Given this list of marker genes Homer1, Slc8b1, Cracr2a, Atp2c2, Tmc1, Ripk1, F2rl3, Htr1a, Galr2, Drd4, Rgs9, Lpar3, Mmp9, Gnas, Cxcl10, Nkain2, Homer2, Adora2a, Ccr1l1, Htr1b, Lrrc52, Stim2, Trem2, Tmx1, Ms4a2, Calm2 (calmodulin 2), Tcaf1, Selenon, Cd4, Atp4a (ATPase, H+/K+ exchanging, gastric, alpha polypeptide), Ubash3b, Prkce, Gnai2, Gja1, Pxk, Atg5, Pdgfrb, Kcnip4, Hbp1, Pdpk1, P2ry6, Kcnip2, Grp (gastrin releasing peptide), Mettl21c, Cacna1c, Vamp2, Trpa1, Gck (NCBI Gene Id 14624), Car7, Pdgfb, Selenok, Trpc6, Tspo, Kcnc2, Tspan18, Lyn, Asph, Epo, Osr1, Atp7a, Ccr1, Ppp3r2, Ucn, Atp8b1, Ccl3, Hrc, Fkbp1b, Cckar, Rnf207, Pkd2, Ubr3, Kcne5, Wnk3, Cxcl1, Gnb2, Vmp1, Gpr35, Tgfb1, Lgals3, Akap5, Cd19, Prnp, Crbn, Nfatc3, Eppin, Akt3, Ffar1, Wnk1, Wnk2, Kcnj15, Bin1, Stim1, Casq1, Asic2, Spg7, Akap7 (A kinase anchor protein 7), Bdkrb1, Cox17, P2rx4, Ahr, Gnao1, Dspp, Scn5a, Kcnj12, Ryr2, Kcnn2, Hcrt, Nos3, Atf4, Pdzk1, Grin2a (glutamate receptor, ionotropic, NMDA2A (epsilon 1)), Prkg2, Kcnn4, Scnn1b, Akt2, Nherf2, Mcub, Dpp6, Jak3, Rgs4, Fgf12 (fibroblast growth factor 12), Snca, Chd7, Cnksr3, Stk39, Kcne1, Cyba, Cacna1g, Sphk2, Il16, Spg11, Usp2, Tesc, Ms4a1, Cacnb3, Gopc, Diaph1 (NCBI Gene Id 28110), Oprk1, Stimate (STIM activating enhancer), Cav3, Slc36a2, Fxyd6, Trpv2, Plcg2, Nkx2-5, Lrrc26, Cxcl9, P2ry1, Cacna2d1, Jph3, Ucp2, Abcb1a, Drd2, Il13, Cacng1, Amigo1, Serpine1, Plcg1, Kcnj2, Cav1, Taco1, Il4, Ank3, Sestd1, Oga, Scn10a, Serpine2, P2rx5, Mchr1 (NCBI Gene Id 207911), Coro1a, Kcne2, Nlgn3, Oprd1, Ctnnb1 (NCBI Gene Id 12387), Chrm1, Lime1, Ccl12, Kcnj10, Fcrl5, Trim27, Pml (promyelocytic leukemia), Stom, Pirt, Rapgef3, Ywhaq, Lilra5, Adrb2, Gnb5, Scn2b, Wnk4, Kif5b, Kcnip1, Grin2d, Glp1r, Kcnab1, Best1, Trpc3, Nedd4, Crh, Inpp5k, Cacna1f, G6pd2, Slc8a1, Cacna1b, Rem1, Orai1, Hfe, Wfs1 (NCBI Gene Id 22393), Atp2b1, Adora1, Snta1, Npsr1, Dhrs7c, Kcnab2, Pawr, Agt, Gjc2, Kcnab3, Hpca, Ikbkb, Rcvrn, Akt1, Jsrp1, Mllt6, Kcnh2, Neto1, Kcng1, Abcb1b, Atp1b1, Cxcl12, Strit1, P2ry12, Lrrc55, Hamp2, Wwp2, Kcnj9, Catsper1, Fyn, Cd63, Slc30a6, Kcnrg, Saraf, Ptger3, Pacsin3, Sptbn4, Ptpn6, Tacr2, Ccl5, Spink1, Rhoa, Ppp3ca, Stac, Jph4 (NCBI Gene Id 319984), Efhb, Flna, Lhcgr, Stac3, Bmp4, Cacnb4, Ngf, Per1, Ntsr1, Trpc1, Nipsnap2, Gpr39, Sgk1, F2r, Vip, Akap9, Cldn16, Slc31a2, Ndufa4, Gnaq, Ptgs2, Lrrc38, Icam1, Car2, Ywhah, Fxyd3, Ehd3, Ano6, Igf1, Stc1, Nedd4l, Ppp3r1, Cacng6, Pln, P2rx1, Scn1b, Ptpn3, Bak1, Abl1 (NCBI Gene Id 98922), Sco1, Adcyap1r1, Cxcr4 (NCBI Gene Id 12767), Psen2 (presenilin 2), Cntn1, Ptpn22, Prkd1, Atp1a1, Vdac1, Drd3, Ahnak, F2, Itgb1, Plcb4, Kcnip3, Dbi, Ednra, Bax, Atp4b, Nol3, Reln, Chp1, Hrh3, Fbxo11, Kcnj5, Hsd3b2, Kcng4, Cxcr3, Atp1a2, Kcnc1, Slc9a1, Dlg1, Cftr, Hap1, Agtr1a, Kcnj16, Cxcl11, Coa8, Fxyd2, Edn1, Htr2a, Abcc9, Gal, Bcl2, Kcnj3, Plcb1, Trdn, Drd1, Egf, Nkain1, Atp1b3, Slc9a3, Best3, G6pdx, Pde4d, Atp2b4, Cx3cl1, Tcirg1, Akap6, Fhl1, P2rx7, Ptk2b, Iscu, Itgb3 (integrin beta 3), Gper1, Ifng, Afg3l2, Adcyap1, Calm1, Hsd3b6, Gstm7, Slc9a6, Hamp, Agrn, Pcsk9, Lcn2 (NCBI Gene Id 99344), Jph2, Arrb2, Ctss, Ppp3cb, Abcc8, Dmpk, Calm3, Dmd, Gria1, Tescl, Tmem38b, Kcna5, Slc26a5, Sumo1, Gsto1 (glutathione S-transferase omega 1), Kcng3, Isl1, Fxyd1, Itpr1, Kcns2, Rgs7, Htr7, Kcnmb1, Tmbim6, Pik3c2a, Kcnj11, Cd84, Adrb1, Tmc2, Mrln, Arf1, Trpc4, 1810037I17Rik, Cldn10, Fxyd4, Prss8, Kcns1, Casr, Cask, Sln, Sri, Lep, Stac2, Myo5a, Actn2, Nkain4, Ywhae, Tgfb2, Cacnb2, Phb2, Clec4b1 (NCBI Gene Id 69810), Aqp2, Gcg, Kcnj4, Fxyd7, Homer3, Ank2, Fgf13, Mylk, Camk2d, Maob, Grin2b, Gimap5, Xcl1, Commd1, Hes1, Kcne3, Dysf, Plpp4, Tspan13 (NCBI Gene Id 66109), Cemip, Cbarp, Kcnj14, Cacna1d, Kcnj8, Kcnj6, Slmap, Oxsr1, Grm6, Kcnq1, Smim6, Crhr2, Tmem168, Tlr9, Grin2c, Nos1, Slc6a4, Zfas1, Stc2, Atp2b2, Fmr1, Kcnj1, Fgf14, Hspa2, Ppp3cc, Creb3, Gramd2a, Camk2a, Aplnr, Bpifa5, Plp1, Casq2, Mtor, Calhm1, Rab11b, Slc30a1, Htt, Pik3cg, Fkbp1a, Gimap3, Vdr, Kcnj13, Bpifa1, Atp2a1, Thy1, Sik1, Dpp10, Nkain3, Ahcyl1, B2m, Epb41, Fxyd5, Cacnb1, Rangrf, Cnr1, Cd300a, Ppif, Edn3, Trpv3, Wfdc6a, Scn4b, Atp1b2, Kcnf1, Scn3b, Tmem38a, Nppa, Ubqln1, Nherf1, Atpsckmt, Tmem74, Nr3c2 (NCBI Gene Id 17363), Kel, Heph, Grin1, Ace, Grin3b, Hsd3b3, Trf, Capn3, Gpd1l, here is a description of the gene set: Any process that modulates the frequency, rate or extent of the directed movement of charged atoms or small charged molecules into, out of or within a cell, or between cells, by means of some agent such as a transporter or pore. Mouse Gene Set: GOBP_REGULATION_OF_MONOATOMIC_ION_TRANSPORT studied in species Mus musculus